Given this list of marker genes CENPA, H2BC9, CENPL, CENPN, H2BC12L, CENPO (centromere protein O), H2AC20, H2BC14, NPM1, RBBP7, RSF1, H2AC14, CENPK, OIP5, CENPT, H2BC4, H2AX, H2BC5, HJURP, CENPI, H4C1, H2BC21, CENPQ, H2BC17, SMARCA5, RUVBL1, RBBP4, ITGB3BP, CENPP, H2AC4, CENPC, CENPW, H2BC26, H2AZ2, H2BC11, CENPH, H2BC15, KNL1, CENPU, CENPX, MIS18A, H2BC13, H2AC18, MIS18BP1, CENPS, H2BC12, H2AB1, CENPM, H2BC3, H2AC7 (NCBI Gene Id 3013), H2BC1, H2AJ, H2AC6, here is a description of the gene set: The formation of centromeric chromatin assembly outside the context of DNA replication involves the assembly of nucleosomes containing the histone H3 variant CenH3 (also called CENP-A). studied in species Homo sapiens Reactome Pathway: Nucleosome assembly part of: Chromosome Maintenance